Given this list of marker genes ZUP1, RAD9A, SNX16, TRAFD1, CMPK2, HPGD, MCL1, SLFN13, EXOC7, CD81, COPA, PAX1 (paired box 1), TSPO, LONP2, CSTF3, SLFN12, PDCD6IP, DBT, RO60, TMEM219, NPHS1, APTX, WBP1L, CDS2, RAP2A, CWC22, NDRG1, ORMDL2, ABCE1, TAF6, SPECC1, ALCAM, CORIN, IRAG2, PSAP (prosaposin), PWP2, SSBP3, DPF2, MDM2, PLA1A, RABGAP1, SPSB1, SNRPA1, TOR1AIP2, RIPK2, AGFG1, BMP8B, GADD45B, SET, SH3BP2, MCF2, F7, PSME2 (proteasome activator subunit 2), CYP1B1, EXOC6, RNPEP, VIPR2, EIF2S1, PACC1, MTARC2, AP2M1, GSTM5, NMNAT3, EPSTI1, C19orf12, SPHK2, POLD2, TUBB4B, DLX3 (distal-less homeobox 3), GBP2 (guanylate binding protein 2), MAPRE2, EZH2, MOV10, CDKN2B, PPP3CB, UBE2D2, IST1, WDR1, ABCF1, CCER1, CSTF2, PABPN1, MS4A7, CCL13, PXN, WDR82, MAPKBP1, NECAB2, IFIT2, FNBP4, SERPINF1, CD200, INPP5D, TOR3A, ZFP64, GNL1, VMP1, NAMPT, TWF2, HNRNPA2B1, SLC13A3, UTP6, DDHD1, ACVR1, MRPS22, LACTB, ARHGAP10, GRAMD2B, NMT1, GNG11, CFAP141, MRPL35 (NCBI Gene Id 64980), GTF3C1, SELENOM, CD40, LAMA3, LIPA, REEP5, LMBR1L, TRIM25, PPP4C, RTCB, MMP14, DR1, YWHAG, SPG11, KRT33A, FGD3, WFS1 (NCBI Gene Id 94141), PMEPA1, MRPL12, KIF5B, CANX, CREB1, FHOD3, RBM42, AGRN, DHX38, ID2, SRSF7, LY9, CYTH3, PSMB10, HSPA8, TRIP12, AVL9, VAMP8, PRRX2, PDLIM4, PAM16, TCERG1, RBM22, ANKRD40, DNAJC14, C5, GBP6 (NCBI Gene Id 163351), FANCA, GEM, UNC50, IGF1, VWA5A, MSH5, PRPSAP2, ALKBH4, IGDCC4, MRPS30, TXNDC9, LSM14B, KCNN3, PGS1, TIMM23, FOXO1, PITPNA (NCBI Gene Id 5306), APOBEC1, NT5C3A, CLEC14A, RAB5IF, DLGAP4, TCTA, VCP, POR, NUPR1, ZMYND19, CCDC86 (NCBI Gene Id 79080), KRT32, DYNC1H1, SYS1, TLNRD1, AARS1, AP1G1, SPDL1, MED17, BLNK, CYFIP1, DCK, KIF20A, TLR1, TNKS2, NIPA2, SUMO3, here is a description of the gene set: species: Homo sapiens mouse primary BMDCs were stimulated with tlr ligands and gene expression changes were profiled on Affymetrix arrays Human Gene Set: GSE17721_PAM3CSK4_VS_CPG_24H_BMDC_DN Genes down-regulated in comparison of dendritic cells (DC) stimulated with Pam3Csk4 (TLR1/2 agonist) at 24 h versus DC cells stimulated with CpG DNA (TLR9 agonist) at 24 h. from publication Amit I, Garber M, Chevrier N, Leite AP, Donner Y, Eisenhaure T, Guttman M, Grenier JK, Li W, Zuk O, Schubert LA, Birditt B, Shay T, Goren A, Zhang X, Smith Z, Deering R, McDonald RC, Cabili M, Bernstein BE, Rinn JL, Meissner A, Root DE, Hacohen N, Regev A (PMID 19729616)